Given this list of marker genes Sytl4, Acsm2, Dscaml1, Ccl20, Ywhaz, Rab9b, Gstm5, Vmn1r66, Rora, Fign, Mmp24, Zbtb41, Orc2, Abca9, Cyb5r2, Diablo, Myo15a, Abhd17b, Iqck, Ranbp6, Lrrc19, Slc6a1, E2f3, Dsg1b, Fkrp, 4930579G24Rik, Mfsd4b5, Kpna6, Arsk, Nup50, Pogk, Fbxl17, Cdh13, Kcnma1, Xpr1, Fam91a1 (NCBI Gene Id 52667), Hbq1b, Elmod1 (ELMO/CED-12 domain containing 1), Luc7l2, Dpf2, Pes1, Prox1, BC035044, Oprl1, Gm1110, Pgd, Tcaf1, Hook3, Tpgs2, Zfp326, Ube2d1, Apobec3 (NCBI Gene Id 80287), Slain2, Shank2, Ranbp9, Dnaja1, Grik1, Chrna6, Clint1, Stx2, Pcdh10, Cpm, here is a description of the gene set: species: Mus musculus from publication Chen Y, Wang X (PMID 31504780) Mouse Gene Set: MIR_7025_5P Genes predicted to be targets of miRBase v22 microRNA mmu_miR_7025_5p in miRDB v6.0 with MirTarget v4 prediction scores > 80 (high confidence targets).